The following is a description of a gene set: Any process that modulates the frequency, rate or extent of potassium ion transmembrane transport. Human Gene Set: GOBP_REGULATION_OF_POTASSIUM_ION_TRANSMEMBRANE_TRANSPORT studied in species Homo sapiens, and this is the list of marker genes: CACNA1D, MIR30D, KCNRG, NPPA, VAMP2, GRP, KCNIP3, KCNN2, BIN1 (NCBI Gene Id 274), KCNIP4, KCNS1, KCNN4, ATP1B3, MIR212, CAV3, PRNP, MIR29B1, ATP1B2, EDN3, ANO6, GALR2, KCNC1, MIR21, OPRK1, KCNE1, KCNS3, KCNIP1, GAL, KCNE3, MIR26A1, KCNS2, MIR103A1, CD63, CAB39, LRRC38, OXSR1, WWP2, KCNIP2, NEDD4L, YWHAE, KCNE5, SUMO1, LRRC55, ATP1B1, KCNAB2, DPP6, FHL1, GNB2, KEL, LRRC26, KCNC2, KCNG1, KCNE2, KCNQ1, AKAP7, NOS1AP, DLG1, AMIGO1, KCNAB1, KCNG4, ABCC9, KCNAB3, ANK2, DPP10, LRRC52, KCNG3, WNK4, RGS4, CAV1, KCNJ2, AKAP6, STK39, KCNH2, FLNA, NEDD4, ANK3